The following is a description of a gene set: Human Gene Set: HP_MULTIPLE_MITOCHONDRIAL_DNA_DELETIONS The presence of multiple deletions of mitochondrial DNA (mtDNA). species: Homo sapiens Multiple mitochondrial DNA deletions, and this is the list of marker genes: POLG2, SLC25A4, POLG, TWNK, MGME1, LIG3, MPV17, DNA2, DGUOK, RRM2B, RRM1, TYMP